The following is a description of a gene set: Human Gene Set: GOBP_REGULATION_OF_LIPID_LOCALIZATION species: Homo sapiens Any process that modulates the frequency, rate or extent of lipid localization., and this is the list of marker genes: NR1H3, PLA2R1, MIR27B, NR1H2, ANXA2P2, EDN1, ZC3H12A, PRAP1, CAV1, MIR33A, ACACB, MIR10B, CRHR1, DBI, GDF9, DENND5B, AVPR1B, MIR145, EPRS1, SAR1B, PPARG, C1QTNF1, POMC, PTPN11, ABCA5 (NCBI Gene Id 55514), PCSK9 (NCBI Gene Id 50983), TNF, CRY1, SPP1, ABCA13, BMP6 (bone morphogenetic protein 6), ATP8A2 (ATPase phospholipid transporting 8A2), MIR33B, TMEM30A, LIPG, PRKN, OXT, CRH (corticotropin releasing hormone), ACSL5, LEP, MIR9-1, MIR144, GAL, MIR17, AKT2 (AKT serine/threonine kinase 2), NTSR1, OSBPL6, AGT, PNPLA2, ABCA12, FURIN (NCBI Gene Id 5123), ATP8A1, TTC39B, MIR130B, MIR27A, LPL, APOA1, PTCH1, KCNK9, MIR206, REPIN1, MIR34A, NMB, CRP, LRAT, ABHD5, ANXA2, IL1B, ACSL1, RETN, GPS2, RXRA, NUS1, MIR301B, PLIN5, PRELID1, P2RX4, APOB, TNFSF11, C3, APOE, THBS1, NAXE, MAPK3, SCARB1, EEPD1, PON1, TNFRSF11A, NFKBIA, MIR185, PLTP, GHRL (ghrelin and obestatin prepropeptide), TAC1, LAMTOR1, PTGES, FASLG, PTPN2, ABCA1, MYB, MIF, SYK, SCP2, PLA2G3, ACSL4, MIR26A1, SEC24A, TSPO, APOC3, ABCA8, PPARD, DISP3, CYP4A11, MIR758, CLSTN3, APOC1, DAB2, CETP, CES1, GALR1, LRP1, MSR1, APOA2, ITGAV (integrin subunit alpha V), LPCAT3, ABCB4, REN, TRIAP1, ERFE, EGF, FIS1, VSTM2A, ABCA3, PRKCD, P2RX7, ZDHHC8, CYP4F2, NKX3-1, CRY2, ITGB3, COMMD1, ARV1, IRS2, SHH, EHD1, SIRT1, MIR148A, KDM5B (NCBI Gene Id 10765), MIR302A, APOA4, APOC4, LDLRAP1, CD36, PLIN3, NFKB1, MIR128-1, IKBKE (NCBI Gene Id 9641), ECRG4, APOC2, IL6, XRCC4, ADIPOQ, PLA2G10, TMF1, ABCA7, CYP19A1, AKT1, AGTR1, MIR19B1, MIR613, ABCA2, ABCG1 (NCBI Gene Id 9619), MIR30C1, SURF4, HILPDA, TMEM97, PLA2G4A, PLIN2, TREM2, YJEFN3, FABP3, SREBF2, MIR93, MIR146A, ABCG4 (NCBI Gene Id 64137), PPARA